The following is a description of a gene set: studied in species Homo sapiens Wide anterior fontanel Enlargement of the anterior fontanelle with respect to age-dependent norms. Human Gene Set: HP_WIDE_ANTERIOR_FONTANEL, and this is the list of marker genes: ALG9, PPIB, MED12, PEX1, SIX2, PEX14, ZMPSTE24, GLI2, DEPDC5, IFT140, DDX3X (DEAD-box helicase 3 X-linked), LRP2, KIF7, TSHB, COL11A1, WNT5A (Wnt family member 5A), MASP1, ETFA (electron transfer flavoprotein subunit alpha), CBFB, PEX10, VPS35L, CDH11, GLIS3, EP300, DLK1, PIGQ, RECQL4, ETFB, SLC25A24, NSUN2, ARX, PIEZO2, ETFDH, ANTXR1 (ANTXR cell adhesion molecule 1), SMG9, PEX19, PEX16, CREBBP, ZFX, ROR2, SOX9, WT1, NAA10, SEC23A, CCDC22, LIG4, FAT4, CRTAP, PEX11B, NDUFAF3, ATP6V0A2, MID1, TWIST1, COG8, NEPRO, SETBP1, MEG3, COG4, FGFR3, GLI3, PEX6, POR, PEX13, DDR2, COL1A1, CDC45, SKI, TALDO1, COL11A2, SH3PXD2B, PEX12, ADAMTS2, DVL1, PPP2R5D, MPDU1, HRAS, PCGF2, KLF1, DICER1, PEX5, CHUK, INTU, PEX2, PEX26, FGFR2, PEX3, EBP, MTOR, COL1A2, RTL1, DCHS1, NSMCE3, COX5A, RNU12 (NCBI Gene Id 574043), B3GLCT, FLNA, P3H1